The following is a description of a gene set: Human Gene Set: HP_HYPOPLASIA_OF_THE_UTERUS Hypoplasia of the uterus species: Homo sapiens Underdevelopment of the uterus., and this is the list of marker genes: CHD7, SOX11, BMPR1B, GNRHR (gonadotropin releasing hormone receptor), DCAF17 (DDB1 and CUL4 associated factor 17), KISS1, WNT4 (Wnt family member 4), POR, NUP107, HNF1B, C14orf39, ESR1, CYP11B1, SPIDR, SPRY4, PROKR2, HCCS, HS6ST1, CYB5A, FIGLA, NDUFB11, KISS1R, KIF14, DUSP6, NSMF, IRF6, ERAL1, MRPS22, FGFR1, SOX9, CLPP, SOHLH1, TACR3, WDR11, MSH5, CYP17A1, GNRH1, ADH5, DHH, PPP2R3C, BMP15, B3GLCT, FOXL2, FGF8, NIN, PROK2, NHLH2, FGF17 (fibroblast growth factor 17), LARS2, TAC3, NR5A1, STRA6, COX7B